The following is a description of a gene set: Hyperplasia of the parathyroid gland. Parathyroid hyperplasia studied in species Homo sapiens Human Gene Set: HP_PARATHYROID_HYPERPLASIA, and this is the list of marker genes: RET, CDKN1A, CDKN2B, KL, IFNG, TSC1, CDKN1B, CDKN2C, MEN1, TSC2